The following is a description of a gene set: Top genes from cluster 6 of acute myeloid leukemia (AML) expression profile; all samples are FAB M1 or M2 subtypes and all samples have internal tundem duplication of FLT3. Human Gene Set: VALK_AML_CLUSTER_6 BACKGROUND: In patients with acute myeloid leukemia (AML) a combination of methods must be used to classify the disease, make therapeutic decisions, and determine the prognosis. However, this combined approach provides correct therapeutic and prognostic information in only 50 percent of cases. METHODS: We determined the gene-expression profiles in samples of peripheral blood or bone marrow from 285 patients with AML using Affymetrix U133A GeneChips containing approximately 13,000 unique genes or expression-signature tags. Data analyses were carried out with Omniviz, significance analysis of microarrays, and prediction analysis of microarrays software. Statistical analyses were performed to determine the prognostic significance of cases of AML with specific molecular signatures. RESULTS: Unsupervised cluster analyses identified 16 groups of patients with AML on the basis of molecular signatures. We identified the genes that defined these clusters and determined the minimal numbers of genes needed to identify prognostically important clusters with a high degree of accuracy. The clustering was driven by the presence of chromosomal lesions (e.g., t(8;21), t(15;17), and inv(16)), particular genetic mutations (CEBPA), and abnormal oncogene expression (EVI1). We identified several novel clusters, some consisting of specimens with normal karyotypes. A unique cluster with a distinctive gene-expression signature included cases of AML with a poor treatment outcome. CONCLUSIONS: Gene-expression profiling allows a comprehensive classification of AML that includes previously identified genetically defined subgroups and a novel cluster with an adverse prognosis. studied in species Homo sapiens from publication Valk PJ, Verhaak RG, Beijen MA, Erpelinck CA, Barjesteh van Waalwijk van Doorn-Khosrovani S, Boer JM, Beverloo HB, Moorhouse MJ, van der Spek PJ, Löwenberg B, Delwel R (PMID 15084694), and this is the list of marker genes: PECAM1, HLA-DRB1, FAM110B, TP53BP1, KIAA0930, DPPA4, DPYSL3, NT5DC3, FTO, DSC2, FOXC1, PIEZO2, XPA, GPC4, CFH, HLA-DPA1, FAM174B, SMC4, HLA-DRA, LTBP1 (latent transforming growth factor beta binding protein 1), BST2, PLXNB1, CEP70, TTC27, ADCY2, HIGD1A, RGS10, CD74, HOXB3, RSL1D1, SLC27A6, FOXF2, CORO1A, SNCAIP